The following is a description of a gene set: species: Homo sapiens Human Gene Set: chr13q22, and this is the list of marker genes: RNY3P7, MYCBP2-AS2, RPL7P44, ENSG00000285572, CLN5, LINC00392, EDNRB, ENSG00000285714, FABP5P1, EDNRB-AS1, LINC00561, ENSG00000285746 (novel pseudogene similar to nuclear pore associated protein 1 (NPAP1)), FBXL3, SRGNP1, RIOK3P1, LINC00347, LINC00446, RNY3P3 (RNY3 pseudogene 3), FAM204CP, ELOCP23, MARK2P12, RN7SL810P, LINC00402, LMO7-AS1, RPL31P54, RPL21P108, MYCBP2, KCTD12, KLF12, RNU6-79P, UCHL3, TBC1D4, RNU4-10P, RN7SL571P, ENSG00000288716, LINC01034, LINC01078, SLAIN1, SSR1P2, OBI1-AS1, SPTLC1P5 (NCBI Gene Id 100874512), MIR3665, KLF5, ENSG00000177596, BTF3P11, CTAGE11P, RNU6-38P, RNU6-66P, DHX9P1, SCEL, COMMD6, LMO7, MYCBP2-AS1, LMO7DN (LMO7 downstream neighbor), RNY1P5, RNY1P8, LINC01069, PSMD10P3, LINC00393, ENSG00000303224, SCEL-AS1, ACOD1